The following is a description of a gene set: Mouse Gene Set: CEBPG_TARGET_GENES Genes containing one or more binding sites for (Cebpg) in their promoter regions (TSS -1000,+100 bp) as identified by GTRD version 20.06 ChIP-seq harmonization. species: Mus musculus from publication Yevshin I, Sharipov R, Kolmykov S, Kondrakhin Y, Kolpakov F (PMID 30445619), and this is the list of marker genes: Hnrnpul2, Snord87, Abraxas2, Gm9936, Gm9905, Gm19710, Gm11335, Hnrnph3, Fn1, Pycr1, Mindy3, Slc7a3, Txndc12, U90926, Atxn2l, Acot2, 1700016P04Rik, Lsg1, 5930430L01Rik, Arl14ep, Vars1, Smarcad1, Ddr2, Prkag2, Slc7a11, Hsp90aa1, Dars2 (NCBI Gene Id 226539), Kdm6b, Slc9a9, Lrrc14, Cd2bp2, Creb5, Gm9946, Dnaja3, Gm5444, Cped1, Ogfod1, Oxsm, E230016M11Rik, Crls1, Sertad2, Dock3, Pde4dip, Gm12022, Arhgef2, Ruvbl2, Runx2os2, Flna, Ccl9, Tecpr1, Rny1, Stk40, Arl1, Lmbrd1, Gm9687, Dcaf6, Cacul1, Hspa9, Pbld2, Slc6a9, Zfp696, Hoxb9, Aqp9, Fgf21, Rbm39, Gm26812, Mrpl54, Bend6, Il6, Arhgap24, Slc25a39, Ppp1r15b, Gm11520 (NCBI Gene Id 103727), Ensa, Ciart, Sf3b2, Elovl1, Dolk, Ran, Dhrs9, Gtpbp4, Sbf2, Eps15, Trpm8, Smurf1, S100pbp, 2900005J15Rik, Snx33, 3110099E03Rik, Wars1, Col1a1, Herpud1, Ark2c, Gpt2, AI987944, Atf6, 4930568A12Rik, Eif4g2, Smad3, Stk25, Frs3, Aff1, Plk3, Large2, Tmco6, E030018B13Rik, Ptbp1, Spata1, Srsf2, Slc1a5, Ptgs2, Tnk2, Ccp110, Fibin, Lhfpl2, Ddit3, Samd8, Fv1, Mpc2, Ptgs2os, Nfe2l1, Orai2, Mrpl33, Ppp1r15a, Zfp385b, Snd1, Zfp365, Gtf2f1, Taf15, Zbtb18, Peds1, Mtus1, Hnrnpdl, Nnt, Pfkp, Mdfic, BC065397, Plekha1, Slit2, Il13ra2, Gars1, Gm17102, Cenpl, Cnn3, Aldh1l2, Fndc7, Snord89, Gtpbp2, Itgb5, Zbtb38, Gm15579, Mdn1, Dnm3os, Atg16l1, Mars1, Pdap1, Morf4l2, Pxdn, Ppp2r5a, Zbtb10, Rad23b, Mcm3, Gm20587, Cars1, Rpia, Igfbp4, Klhdc3 (NCBI Gene Id 71765), Eif1, Tomm6, Lztfl1, Cldn12, Hsd3b1, Wdr25, Necap2, Nup35, Btf3l4, Msantd7, Kifc5b, Tor3a, Iars1, Tbce, Mea1, H3c7, Tars1, Foxp1, Xbp1, Spen, Pcdh11x (protocadherin 11 X-linked), Gm4925, Slc1a4, Soat2, Abraxas1, Abcc5, Ss18l2, Tnks1bp1, Mir1932, Cass4, Rgs12, Rps6kb2, Ssu72, Frat2, Bltp3a, Smad6, Bud31, Ankmy1, Gm12258 (NCBI Gene Id 237769), Cr1l, Scpep1, Psat1, Pex16, Gys1, Atf3, Slc7a7, Nf1, Slc20a1, A130050O07Rik, Mideas, Ccdc186, AW209491, D5Ertd579e, Tbrg1, Phyhd1, Lockd, Gm22200, Micu3, 4930519G04Rik, Gm13073, Trp53cor1, Slc45a4, Clcn6, Plekhh3, Gm15417, Apobec1, Pard3, Nisch, Sh3bp5l, Eif2s2, A530013C23Rik, H4c14, Plekha4, Gne, Gm9929, Gm15764, Becn1, Cotl1, Tnfaip6, Acaa1a, Fpgs, Rusc2, Vldlr, Phf10, Gdf9, Trib3, Cp, Recql, Nudt21, Slc16a14, Rcc2, Hjurp, Ptpn12, Cdnf, Csnk1g2, Pkdcc, Ormdl3, H1f8, Zfp672, Marchf6, Thap6, Mff, Jdp2, Gm27042, Inpp5b, Ptpn22, Enc1, Dhrs7, Taco1, Smim10l1, Glrp1, Rpl13a, Hax1, Gm15413, Gm10484 (predicted gene 10484), Bcat1, Atp13a3, Mir199a-2, Hmox1, Ttc9c, Lars1, Slc19a2, Ipmk, Capn10, Mfsd11, Ank2, Prmt3, Gm37754, Pafah1b2, Miip (migration and invasion inhibitory protein), Esyt1, Tnfaip2, Usp2, Gm16253, Spty2d1, Yars1, Gm12518, Mthfr, Clcn3, Gm25703, Cox6a2, Fdxr, Eif4a1, Ptges, Knl1, Aldh18a1, Alkbh3os1, Rbm4, Ap5s1, Josd1, Serpinf1, Naaa, Ubr2, Pacsin2 (NCBI Gene Id 23970), Pck2, Calcrl, Dhx33, Mbnl2, Il6ra, Htra1, Kifc1, Tac1, Atg10, Cebpg, Ywhag, Uqcrq, Sh2d6, Psen2, Nsun4, Prkg2, Trim66, Fam161a, Recql4, Got1, Nupr1, Uvssa, Nars1, Smarca2, Kat7, Il1rl2, Dclre1c, Aars1, Creld1, Trim46, Asns, P2rx3, Abhd11, Rnf11, Chac1, Cry2